Given this list of marker genes Renbp, Amdhd2, Nagk, Npl, Gnpda1, Gnpda2, here is a description of the gene set: The chemical reactions and pathways resulting in the breakdown of N-acetylneuraminate, the anion of 5-(acetylamino)-3,5-dideoxy-D-glycero-D-galacto-non-3-ulosonic acid. studied in species Mus musculus Mouse Gene Set: GOBP_N_ACETYLNEURAMINATE_CATABOLIC_PROCESS